Given this list of marker genes CLK2 (NCBI Gene Id 1196), SLAMF6, SYDE2, DDI1, CTSS, SLC2A9, ARID5A, XPC, TMOD4, OXCT1 (3-oxoacid CoA-transferase 1), RSAD2, RO60, IZUMO4, PMEPA1, DUSP28, ZFP36, LTB, KLF2, ASPHD1, CXCR4, CCDC175, WLS, CHST15, FSCN3, ATG13, ZNF365, ACP3, LRP12, FAM13B, RNF151 (ring finger protein 151), OTUD7A, KCNC4, ARID5B, MBOAT1, MYORG, SPECC1, TNS1, ATN1, STX1A, LINC00511, CELSR1, IL6R, CAPSL, FAH, MC5R, RPS6KL1, NEK3, FBXL5 (NCBI Gene Id 26234), FSD2, FGF13, CDC42SE1, ATP2B2, FRMD8, NARS1, LCMT2, TLR7, CD79B, SPRY1, ABT1 (activator of basal transcription 1), CDKL3, HOOK2, MLC1, CANT1, UROD, SLC15A2, LGALS7, MOS, TMEM238L, TLR6, GPR146, ARMC3, ST8SIA3, SULT1B1, STK38, STK4, SSBP2, GBP2, IFT81, THADA, HCRTR1, ALKBH4, MS4A6A (NCBI Gene Id 64231), TGFB1I1, PARVB, ZNF281, HMG20B, ZSCAN12, MLH3, SAMHD1, TEX35, ZUP1, C11orf68, TSSK1B, LMAN2L, BPHL, TLR3, SIDT1, CD6 (NCBI Gene Id 923), ARHGEF12, SLAMF1, PPP2R5A, CDON, IFT140 (intraflagellar transport 140), TREML2, SLCO3A1, ERMARD, MATCAP1, CFAP161, RGS12, STXBP4, KRBA1, PCGF1, BOK, FTSJ3, PRND, ATF7IP, POLR3C, IGKC, DDC, IFIH1, JUN, CD200, MCC (MCC regulator of WNT signaling pathway), ARL4A, HDAC4, SYTL4, NTHL1, KCNA3, TMEM192, CD1D, UBE2L6, PLGRKT, ABI3, PRG3, ERCC5, FKBP4, PPP1R3F, GPRASP1, EARS2, CDKN2D, LIAT1, ACAA2 (NCBI Gene Id 147548), YPEL5, RNF19B, GABBR1, EPHX1, ZNF804A, RLF, SLPI, SH3BP1, RDH5, PARP3, HVCN1, RNASEL, IRF1, RTF2, HCN3, VIPR1, GALNT10, TMIE, HK1, INPP5K, SLC9B2, RIGI, EMC9, BCKDHA, GABRA4, TRIM14, TSPAN5, ARHGAP32, IGHM, MYCBP2, TLR1, TCF7, NTPCR, WDR45, HSD17B11, LYRM2, ZNF622, IL21R, MTMR9, IPCEF1, DENND2D, CD2AP, ITK, CACNG1, ZFP64, MYL6B, MXRA8, ITGAE, CLCN6, TBRG1, PBX4, OVGP1, CCR4, CMTR1, SOX12, SLC26A11, RCVRN, AKAP12, here is a description of the gene set: Genes down-regulated in follicular B cells versus those stimulated with anti-IgM and CD40 for 6h. To obtain insight into the genetic basis of the increase of functional activity of memory B cells over time, we compared the gene expression profiles of day 7 and day 40 NP-specific/IgG1 memory B cells, GC B cells and plasma cells in immunized WT mice and naïve B cells, before and after activation in vitro. Human Gene Set: GSE11961_UNSTIM_VS_ANTI_IGM_AND_CD40_STIM_6H_FOLLICULAR_BCELL_DN species: Homo sapiens from publication Kaji T, Ishige A, Hikida M, Taka J, Hijikata A, Kubo M, Nagashima T, Takahashi Y, Kurosaki T, Okada M, Ohara O, Rajewsky K, Takemori T (PMID 23027924)